Given this list of marker genes Neil3, Fanca (NCBI Gene Id 52324), Cenpx, Fan1, Faap20, Fancd2, Fancf, Exo5, Faap24, Fancc, Sprtn, Ercc6l2, Fancg, Xpa, Vcp (valosin containing protein), Faap100, Poln, Mcm8 (minichromosome maintenance 8 homologous recombination repair factor), Mcm9, Cenps (centromere protein S), Nucks1, Ercc4, Dclre1b, Hmces, Firrm, Xrcc3, Rfwd3, Rad51, Dclre1c, Fancm (NCBI Gene Id 52599), Rad51d, Fancl, Dclre1a, Fancb, Rad51ap1 (RAD51 associated protein 1), Hrob, Ercc1, here is a description of the gene set: species: Mus musculus Mouse Gene Set: GOBP_INTERSTRAND_CROSS_LINK_REPAIR Removal of a DNA interstrand crosslink (a covalent attachment of DNA bases on opposite strands of the DNA) and restoration of the DNA. DNA interstrand crosslinks occur when both strands of duplex DNA are covalently tethered together (e.g. by an exogenous or endogenous agent), thus preventing the strand unwinding necessary for essential DNA functions such as transcription and replication.